Given this list of marker genes PIAS1, DNAJC5G, RBBP7, AP4M1, HMGN2, SPTSSB, SMC1A (NCBI Gene Id 8243), CTNND2, NFATC2IP, ZBTB8OS, PRPS1, E2F3, PIM1, ING3 (NCBI Gene Id 54556), MAT2A, NASP, SRSF2, RTF1, KMT5A, NUP153, PHF13, SMAD6, RAB11B, GAPDH, RAD51, PDS5B, ZCCHC8, INTS7, RHD, PRRC2C, MCM8, PEG3, EIF1AX, DNAJC11, PCSK1, SLC25A14, PLK4, ANKHD1-EIF4EBP3, CTCF, DDX17, CBX5, KIF15, TRIM47, ERBIN (erbb2 interacting protein), H2BC10, MAZ, SHMT1, SMC3, DDB2, DMD, MCM3, TRIR, PDS5A, ZNF362, PPP1CC, ARHGAP6, UFD1, ZSWIM9, STT3B, H1-3, KBTBD7, FMO4, ZNF565, CPNE5, ZNF827 (zinc finger protein 827), LIG1, H2BC12, EPHB2, PAQR4, PODN, PAPOLG, FLI1, CTDSP1, MCM4, NPR3, MCM6, CDC6, SASS6, POLA2, RIBC1, SLC38A1, JADE2, STK35, SREK1, EZH2, MXD3, ZMYM2, TCP1, INSM1, KLF4, GPAT2, DNMT1, ARID4A, SRSF1, ADAMTS2, MEIS1, SIK2, ADCY8, CDK1, PRKDC, ONECUT1, TOPBP1, YTHDC1, JPH1, JADE1 (jade family PHD finger 1), SLC25A3, CDC45, CASP8AP2, KIAA1143, TBX3, PCSK4, NSD3, ID3, PKMYT1, GPN3, SSBP3, KPNB1, GRIK2, CLTA, GMNN, ST20-AS1, KCNA1, WEE1, UNG, MRPL18, OTUD7B, MEIS2, IER5L, USP1, RBPJ, KCND2, PELP1, CDC20B, CDC25A, NDUFA11, ANKHD1, SIX5, ABCF2, NRP2, RANBP1, ZBTB25, DOLK (dolichol kinase), BARHL1, SEZ6, PCYT2, PCNA, EPHB1, STAG2, DLST, NCL, TREX2, ZNF653, MCM7, TFRC, ZNF367, GCH1, KLF5, ATRX, TMEM187, PPME1, PHF12, HNRNPD, ZIM2, NIPBL, TMEM255A, UXT, HNRNPA1 (heterogeneous nuclear ribonucleoprotein A1), CACNA1G, SERBP1, SLC6A4 (NCBI Gene Id 6532), OVOL2, TIPIN, NECTIN1, CNOT3, TENT5B, NOL4, FAM120C, CDCA7, USP49, IMPDH2, HS6ST3, PPP1R8, IPO7, TIGAR, TRMT6, H2AZ1, DCTPP1, SALL1, H2AC12, SMC6, E2F7, GEN1, SYT11, ATE1, AP1S2, TRMT13, FAM216A, FBXO5, RFC1, TBX6, STMN1, PRPF38A, ATAD2, TRMT2A, E2F8, ATXN7L2, ASCL1, CTDSPL2, ORC1, RHCE, SMG1, POLA1, MCM2 (NCBI Gene Id 94687), BAG6, LASP1, POLE2, MDGA1 (MAM domain containing glycosylphosphatidylinositol anchor 1), E2F1, FOXO3, SNPH, DPYSL2, RBBP4, LHX5, RABL6 (RAB, member RAS oncogene family like 6), SEMA5A, ARHGAP11A, DCK (deoxycytidine kinase), OLFML3 (olfactomedin like 3), here is a description of the gene set: studied in species Homo sapiens Human Gene Set: E2F_Q3 Genes having at least one occurrence of the motif TTTCGCGC in the regions spanning 4 kb centered on their transcription starting sites. This matches the transcription factor binding site V$E2F_Q3 (v7.4 TRANSFAC).